The following is a description of a gene set: The series of molecular signals initiated by interleukin-3 binding to its receptor on the surface of a target cell, and ending with the regulation of a downstream cellular process, e.g. transcription. species: Mus musculus Mouse Gene Set: GOBP_INTERLEUKIN_3_MEDIATED_SIGNALING_PATHWAY, and this is the list of marker genes: Csf2rb, Csf2rb2, Il3ra, Il3, Syk, Jak2, Fcer1g, Stat5a